Given this list of marker genes TNFRSF10B, CASP8, FAS, TNFRSF10A, FASLG, CFLAR, TRADD, TRAF2, FADD, TNFSF10, RIPK1 (receptor interacting serine/threonine kinase 1), here is a description of the gene set: species: Homo sapiens Reactome Pathway: Regulation by c-FLIP part of: Caspase activation via Death Receptors in the presence of ligand c-FLIP proteins (CASP8 and FADD-like apoptosis regulators or c-FLICE inhibitory proteins) are death effector domain (DED)-containing proteins that are recruited to the death-inducing signaling complex (DISC) to regulate activation of caspases-8. Three out of 13 distinct spliced variants of c-FLIP had been found to be expressed at the protein level, the 26 kDa short form FLIP(S), the 24 kDa form FLIP(R), and the 55 kDa long form FLIP(L) (Irmler M et al. 1997; Shu HB et al. 1997; Srinivasula SM et al. 1997; Scaffidi C et al. 1999; Golks A et al. 2005; Haag C et al. 2011)<p>All c-FLIP proteins carry two DEDs at their N termini, which can bind FADD and procaspase-8. In addition to two DEDs, FLIP(L) contains a large (p20) and a small (p12) caspase-like domain without catalytic activity. FLIP(S) and FLIP(R) consist of two DEDs and a small C terminus. Depending on its level of expression FLIP(L) may function as an anti-apoptotic or pro-apoptotic factor, while FLIP(S) and FLIP(R) protect cells from apoptosis by blocking the processing of caspase-8 at the receptor level (Scaffidi C et al. 1999; Golks A et al. 2005; Toivonen HT et al. 2011; Fricker N et al. 2010).